Given this list of marker genes FLRT2, DSTYK, WNT4, ITGB1, SNCA, FGF17, FGFRL1, GCLC, ZDHHC16, SHISA2 (shisa family member 2), FGF14, IQGAP1, PRDM14, FGF16, FGFBP1, NOG (noggin), NPR2, NGFR (NCBI Gene Id 4804), CD44, CTNNB1, FGF21, ZFP36L2 (ZFP36 ring finger protein like 2), CXCL8, KIF16B, APLN, FGF8, FGF19, SULF2, FGF20, NPTN, MIR15A, CCL5, COL1A1, FGFBP3, FGF2, OFD1, MIR573, LRIT3, GATA3, CEP57, FGF4, NDNF, CXCL13 (NCBI Gene Id 115545), NDST1, FAM20C, CASR, FGFR4, OTX2, CCN2, EGR3, RHOD, IER2, FGF12, CPS1, KDM5B, FLRT3, HHIP, FGFR2, TBX2, GRB2, NR4A1, MIR503, FUZ, PRKD2, KL, SHCBP1, FRS2, FGFR3, KCNC1, WNT5A, ELK1, SCGB1A1, CCL2, FGF1, THBS1, POSTN, ITGB1BP1, GPC1, ZFP36L1, SPRY4, CRKL, FGF23, TBX1, SPRY1, LHX1, FGF6, KLB (NCBI Gene Id 152831), CREB3L1, GCLM, SMOC2, PTH, FGF5, MIR16-1, SPRY3, PTPN1, FGF7, MIR424, RAB14, TRIM71, ZFP36, SULF1, MIR149, MIR1-1, HYAL2, FGFR1, CRIPTO, SOS1, EXT1, FGF18, IFT80, FGF3, FIBP, FLRT1, FGF10, MIR339, GALNT3, PTPN11, DLL4, CHURC1, FGF9, FGF22, EXT2, HYAL1, NRXN1, RUNX2, SHOC2, TNC, SPRY2, FRS3, MIR146A, here is a description of the gene set: Any process that results in a change in state or activity of a cell or an organism (in terms of movement, secretion, enzyme production, gene expression, etc.) as a result of a fibroblast growth factor stimulus. studied in species Homo sapiens Human Gene Set: GOBP_RESPONSE_TO_FIBROBLAST_GROWTH_FACTOR